The following is a description of a gene set: Presence of multiple polyps in the duodenum. species: Homo sapiens Duodenal polyposis Human Gene Set: HP_DUODENAL_POLYPOSIS, and this is the list of marker genes: APC, SMAD4, MSH3, ENG, BMPR1A